The following is a description of a gene set: Benzopyrenre to CYP-mediated metabolism. Pathway ID: N01401. Pathway type: Env factor. Pathway class: nt06251 CYP-mediated ROS formation. Human Gene Set: KEGG_MEDICUS_ENV_FACTOR_BENZO_A_PYRENRE_TO_CYP_MEDIATED_METABOLISM species: Homo sapiens Pathway Definition from KEGG: BP -- (CYP1A1,CYP1B1) >> EH >> AKR -> C22355 -> Semiquinone -> Superoxide, and this is the list of marker genes: AKR1C3, AKR1C1, AKR1C4, AKR1A1, CYP1B1, EPHX3, EPHX4, EPHX2, CYP1A1, AKR1C2 (NCBI Gene Id 6994), EPHX1